The following is a description of a gene set: Mouse Gene Set: REACTOME_N_GLYCAN_TRIMMING_AND_ELONGATION_IN_THE_CIS_GOLGI studied in species Mus musculus N-glycan trimming and elongation in the cis-Golgi, and this is the list of marker genes: Man1a2, Man1a, Man1c1, Manea (NCBI Gene Id 242362), Mgat1